The following is a description of a gene set: studied in species Homo sapiens Human Gene Set: TGTGTGA_MIR377 Genes having at least one occurence of the motif TGTGTGA in their 3' untranslated region. The motif represents putative target (that is, seed match) of human mature miRNA hsa-miR-377 (v7.1 miRBase)., and this is the list of marker genes: HDAC9, NKX2-2, HOXB8, PTMA, PLCB1, TP63, CUL4A, CD93, ITPRID2, CAMTA1, OSGIN2, KPNB1, RNF145, PRX, LMX1A, ARGLU1, IPO5, TAPT1, KLHL9, KLK10, KMT2A, ARK2C, HOXC6, LRP12, BAZ2B, TTC23L, FAT2, KLHL2, PRP4K, AZIN1, FCHSD1, CDON, SLC39A10, TEAD1, AMACR, ZBTB4, MADD, CPLX3, PHF3, EIF4E, NDEL1 (nudE neurodevelopment protein 1 like 1), JAZF1, RASA1, EFL1, NT5C3B (5'-nucleotidase, cytosolic IIIB), CRB3, BIRC8, MDM2, PDGFRA, BTBD7, ARHGAP21, ZFX, CPSF6, PHF21A (PHD finger protein 21A), CTCF, ARMC8, DLGAP4, PRKD1, ARID1A, PITX2, NSD2, SLC35C2, FUT8, EDNRB, CPEB4, UBE2L3, MAX, TRMT11 (tRNA methyltransferase 11 homolog), PUM1, NBEA, PPM1F, ATXN2L, SUGP1, NEGR1, FNBP1L, H3-3A, NUP153, HMOX1, FAM133B, EYA4, MAP1A, TM9SF1, QKI, RNF182, SLC22A2, ARID4B, CCDC184, MMP16, JAG1, CNOT7, KIF2A, HMBOX1, HAO2, BCL2L1, RPGRIP1L, BAZ2A, STRN4, RNF38, CSRNP3, CAMK2N2, NCOA1, C5orf24, CELF2, ZEB2, DMTN, EGR1, INTS4P1, KLHL35, CACNA2D2, CUL1, RBPMS, FLNC, NRG1, H6PD, ADARB1, VCPIP1, XIAP, GLYR1, RPS6KB1, UBE2D2, C2CD2L, TMX1, ILRUN, PRTG, S1PR1, ABCA9, PSME4, PTPRN, MACF1, MVB12B, MINAR1, ADRA2B, GGA3, HAPSTR1, NRK, SLC11A2, NPEPPS, PCDH10, HS2ST1, FZD4, PRR7, NR6A1, PHF6, NAPB, MIER1, ZDHHC14, NCOA6, CDKN1B, STK35, AGPAT4, RET, GRSF1, LAMC1, SRPK2, RICTOR, RSBN1, ZFP36L1, SRSF1, CREBL2, DNAJC6, ZNF462, ATXN7, CCDC32, MARCHF3, UNC45A, GTPBP8, GPR85, ETS1, C21orf91, DHCR24, ARL8B, CD24, NAA15, ARID1B, SOD1, ATXN1, CAPN5, SRF, FOXN3, OTULIN, SUMF1, EGR2, SLC6A8, NELFA, TRIOBP, TRIP12, REEP1, EP300, FBXO30, ATXN7L1, TMED2, RABGAP1, MRFAP1, VEGFA, THADA, CAP2, UBP1, FMR1, KCNMA1, CARTPT